The following is a description of a gene set: species: Homo sapiens Human Gene Set: REACTOME_MET_ACTIVATES_PTK2_SIGNALING MET activates PTK2 signaling, and this is the list of marker genes: COL27A1, COL1A2, COL3A1, LAMA5, LAMA1, COL5A2, LAMC2, COL1A1, HGF, PTK2, LAMB3, MET, SRC, ITGA3 (NCBI Gene Id 4454), COL11A2, FN1, COL5A3, COL5A1, LAMB2, ITGA2, LAMA3 (laminin subunit alpha 3), LAMC1, LAMA4, LAMB1, ITGB1, LAMA2, COL11A1, LAMC3, COL2A1, COL24A1